Given this list of marker genes TRIM5, ZFYVE1, ULK1, ATG14, EMC6, here is a description of the gene set: Human Gene Set: GOCC_OMEGASOME species: Homo sapiens Omega-shaped (as in the Greek capital letter) intracellular membrane-bounded organelle enriched in phosphatidylinositol 3-phosphate and dynamically connected to the endoplasmic reticulum. Omegasomes are the first step of the formation of autophagosomes via the phagophore assembly sites.